Given this list of marker genes Cyp1b1, Ephx2, Cyp2j6, Cyp2c66, Cyp2c65, Cyp1a2, Cyp1a1, here is a description of the gene set: This event has been computationally inferred from an event that has been demonstrated in another species.<p>The inference is based on the homology mapping from PANTHER. Briefly, reactions for which all involved PhysicalEntities (in input, output and catalyst) have a mapped orthologue/paralogue (for complexes at least 75% of components must have a mapping) are inferred to the other species. part of: Arachidonate metabolism electronically inferred by orthology from the curated human pathway Reactome Pathway: Synthesis of epoxy (EET) and dihydroxyeicosatrienoic acids (DHET) studied in species Mus musculus